Given this list of marker genes SLC3A2, SLC43A2, CTNS, SLC1A4, SLC7A13, SLC1A1, SLC3A1, NFE2L1, SLC1A2, SLC7A9, SLC7A5, SLC7A11, MFSD12, here is a description of the gene set: studied in species Homo sapiens The directed movement of amino acids containing sulfur (cystine, methionine and their derivatives) into, out of or within a cell, or between cells, by means of some agent such as a transporter or pore. Human Gene Set: GOBP_SULFUR_AMINO_ACID_TRANSPORT